Given this list of marker genes Chek2 (checkpoint kinase 2), Rfc3, H2bc13, H4c3, H4c12, Mdc1, H2bc7, Rad1, Dna2, Rad9a, H4c14, H4c9, H2bc9, Ywhah, Rpa1, H4c17, Ccna1, H4c11, Trp53bp1, Nbn, H2bc15, H2ax, H2bc3, Kat5, H2bc12, Ube2n, Ywhae, Trp53, Rnf168 (ring finger protein 168), Pias4, H4c6, Wee1, Wrn, Blm, H4c2, Ccnb1, Cdc25c, Bard1, Mre11a, H4c1, H4c4, Brca1, Babam1, Rbbp8, Brcc3, Cdk1, H2bc8 (NCBI Gene Id 319181), H2bc11, Hus1, H4c8, Top3a, H4c18, H2bc27, H2bc22, Sfn, H2bc1, here is a description of the gene set: part of: G2/M Checkpoints electronically inferred by orthology from the curated human pathway studied in species Mus musculus This event has been computationally inferred from an event that has been demonstrated in another species.<p>The inference is based on the homology mapping from PANTHER. Briefly, reactions for which all involved PhysicalEntities (in input, output and catalyst) have a mapped orthologue/paralogue (for complexes at least 75% of components must have a mapping) are inferred to the other species. Reactome Pathway: G2/M DNA damage checkpoint